Given this list of marker genes SLC39A1, PCDH7, WDR33, PCSK6, B3GALT1, SEC62, TRIP13, ARHGEF7, CACNA2D1, TIFA, CNOT6, LMO4, TCF12, MFSD14A, PCDH9, GALK2, DUXA, ANKRD34A, PLEKHA3, PSMD11 (NCBI Gene Id 5717), TMEM215, TMEM220, ZNF302 (zinc finger protein 302), REEP1, APC, PROS1, SLC26A7, KANK1, PTPN13, RBM4 (NCBI Gene Id 5936), KNG1, KLHL36, IGFBP1, SLC39A14, GLCE, TGM2 (transglutaminase 2), UGGT1, PATJ, GOLPH3, RAD51D, TSHZ2, PCDH8, JAKMIP3, WDR11, SAP30BP, RHOQ, MEF2C, GSR, FBXW7, ARL5B, ABHD18, RNF180, DGKA, PPFIA1, KAT6A, ARID1B, PNISR, MAP2, FOXP2, ATXN1, DLX1 (NCBI Gene Id 1745), ZBTB20, ZFP36L2, ANKRD12, FIGNL2, NR3C1, CCNH, DENND4C, NPTX1, SNAP25, LIMA1, C1D, ARIH1, XRCC2, CDYL2, CEP68, VWC2, SSBP2, ZDHHC11, TRIO, ZC3H12C, MED13, HECTD2, TNRC6B (NCBI Gene Id 23112), KCNN3, ZPLD1, BPNT1, MECR, ZIM3, GLRA3, PRRG1, ARPP21, CLCN3, RAP1A, CHD1, PRKN, PAM, BACE1, SPRY2, TENT4B, RNF2, PSMG2, HTR2C, NHLRC2, ADCY2, PRNP, DMD, HDAC9, ZNF644, here is a description of the gene set: from publication Chen Y, Wang X (PMID 31504780) Genes predicted to be targets of miRBase v22 microRNA hsa-miR-4693-5p in miRDB v6.0 with MirTarget v4 prediction scores > 80 (high confidence targets). studied in species Homo sapiens Human Gene Set: MIR4693_5P